The following is a description of a gene set: from publication Chen Y, Wang X (PMID 31504780) Human Gene Set: MIR4793_5P Genes predicted to be targets of miRBase v22 microRNA hsa-miR-4793-5p in miRDB v6.0 with MirTarget v4 prediction scores > 80 (high confidence targets). species: Homo sapiens, and this is the list of marker genes: ZC3H15 (zinc finger CCCH-type containing 15), BAGE2, TAP2, SMAD4, RBM41, BBS4, FZD10, SPANXN5, ARID2, CHM, BCDIN3D, H3-3B, DOCK9, APP, KRTAP6-3, SPRY3, UQCRB, VLDLR, BET1L, XPR1, PDCD10, ASXL2, OPCML, TLR2, ATF2, STRN, ERCC6L2, EXOC6B, PLPP3, PCDHA2, SUSD6, ATP6V0E1, ZNF706, CUX2, SLC2A14, MAP2K1, ESRRG, ATP2C1, TCF12, MDM4, ELAVL2, PDE1C, ARHGEF12 (NCBI Gene Id 55406), INPP5D, ARHGAP40, ARHGAP11A, TBC1D9, REPS2, PMM2, H3-5, CHIC1, LEPR, GRAMD2B, B3GNT9, CTDSPL, SCN2A, BEND4, PPP2R5E, ANKH, ACTC1, SPANXN1, MED13, ERC1, IGF1, WDR64, SLC2A3, UTP14C, FOXN2, ITGAE, SHISAL1, SLC45A3, NCKIPSD, SNX1, PPM1A